The following is a description of a gene set: studied in species Mus musculus Any process that activates or increases the frequency, rate or extent of the chemical reactions and pathways involving lipoproteins, any conjugated, water-soluble protein in which the nonprotein group consists of a lipid or lipids. Mouse Gene Set: GOBP_POSITIVE_REGULATION_OF_LIPOPROTEIN_METABOLIC_PROCESS, and this is the list of marker genes: Pemt, Rab3gap2, Svip, Rab3gap1, Pik3c3, Gba1